The following is a description of a gene set: Mouse Gene Set: GOBP_MITOCHONDRION_ORGANIZATION A process that is carried out at the cellular level which results in the assembly, arrangement of constituent parts, or disassembly of a mitochondrion; includes mitochondrial morphogenesis and distribution, and replication of the mitochondrial genome as well as synthesis of new mitochondrial components. studied in species Mus musculus, and this is the list of marker genes: Sirt7, Bloc1s2, Ndufaf8, Endog, Ndufa13, Mrpl15, Slc25a31, Dap3, 2610042L04Rik, Ghitm, Snca, Bok, Atp13a2, Triap1, Pparg, Htt, Twnk, Sesn2, Camkmt, Septin4, Gclc, Lncbate1, Fancg, Man2a1, Mtm1, Fmc1, Adck1, Hdac6, Akt3, Dctn6, Prelid1, Hsp90aa1, Letmd1, Kif28, mt-Nd5, Chchd7, Mcu, Flvcr2, Timm50, Fbxo24 (F-box protein 24), Atp7a, Mapt, Golph3, Higd1b, Gabpb1, Primpol, Ndufa2, Irgm2, Thg1l, Tmem242, Pyroxd2, Bmf, Immt, Ptcd2, Kdr, Timm29 (translocase of inner mitochondrial membrane 29), Mief1, Ndufb9, Plaur, Bcs1l, Ndufa8, Sh3glb1, Tmem135, Pex5, Mff, Cox7a1 (NCBI Gene Id 12865), Ndufb11, Opa3 (NCBI Gene Id 403187), Ndufa11, Jtb, Cav2, Bnip3, Ndufaf4, Carlr, Bik, Epm2a, Nsun7, Nipsnap2, Micu1, Ddhd1, Chchd10, Atp23, Prmt6, Cebpa, Cyrib, Slc25a4, Akt1 (thymoma viral proto-oncogene 1), Ndufaf1, Lmna, Parp1, Mtx2 (metaxin 2), Vat1, Chchd4, Pld6, Afg3l2, Moap1 (modulator of apoptosis 1), Eya2, Proca1, Bid, Lipa, Gsk3b, Lyrm2, Ndufa5, Ndufa6, Ppargc1a, Ndufb6, Poldip2, Sdhaf4, Bcl2a1a, Mtx3, 4930550C14Rik, Cxadr, Opa1, Bcl2l10, Polg, Plscr3, Mtnap1, Ppp2cb, Surf1, Nectin2, Cp, Pnpt1, Igf1, Fastkd3, Rnaseh1, Ppif, Rab3a, Slc25a36, Stoml2, Tomm22, Dynlt1b, Ndufa3, Atp5if1, Acad9, Micos10, Atp5f1d, Ndufa9, Bax, Pet117, Neurl4, Cdk5, Plec, Norad, Cfh, Mir133a-1hg, Ednra, Ndufb11b, Bbc3, Mapk9, Mrpl39, Tmem102 (NCBI Gene Id 380705), Bcl2l13, Stat2, Fis1, Rnf7, Fas, Bcl2, Atf2, Fxn, Vps35, Mtfr1 (NCBI Gene Id 76994), Uqcc4, Rab29, Agk, Htra2, Pim2, Atg7, Ggnbp1, Stat3 (signal transducer and activator of transcription 3), Oxa1l, Cntnap1, Epas1, Hgf, Tmem14a, Mir361, Mtch1, Romo1, Selenon, Uqcc6, Park7, Marchf5, Tymp, Usp30, Dnm1l, Mfn1, Adgrg6, Psmd10, Mcl1, Ndufs2, Hrk, Hk2, Ndufa1, Dynlt1c, Lpin1, Agtpbp1, Spata18, Ndufs8, mt-Nd4, Bad, Ep300, Gclm, Fzd9, Mgme1 (NCBI Gene Id 98953), Mup3, Ctcf, Dynlt1a, Rab32, Dnaja3, ENSMUSG00000126352, Atad3a, Mmp9, Siva1, Mpv17l, Mtfp1, Mtfr1l, Mfn2, Ddhd2, Uqcc3, Bcl2a1c, Dynlt1f, Nubpl, Huwe1, Camk2a, Fsip1, Tert, Msto1, Marcks, Slc25a5, Polg2, Wasf1, mt-Nd6, Bcl2l1, Cox16, Aifm1, Pdcd5-ps, Bcl2l11, Gimap3, Pink1, Phb1, Pisd, Gdap1, Fam3a, Timm10, Cox10, Mfsd14a, Dnajc11, Atpaf1, Abcc9, Prkn, Ccar2, Apool, Map3k1, Aifm2, Hmgcl, Nptx1, Atg3, Ndufs6, Ndufc2, Fez1, Tmem11, Wdr81 (WD repeat domain 81), Mup5, Ier3, Mir668 (microRNA 668), Timm9, Bcl2a1b, Mef2a, Ndufb4b, Top3a, Mpv17, Rhot1, Ssbp1, Ndufaf7, Alkbh7, mt-Nd1, Rab38, Sfn, Tug1, Myc, Slc9a1, Slc22a5, Cert1, Ndufb3, Armcx3, Atp2a1, Rrm2b, Miga1, Avp, Uqcc5, Tafazzin, Nme3, Chchd2, Ndufb1, Tfam, Timm13, Pum2, Stox1, Vps13a, Cck, Pgam5, Col6a1, Hip1r, Lyrm7, Dna2, Cibar1, Irgm1, Ndufaf6, Noa1, Letm2, Cep89 (centrosomal protein 89), Ndufs3, Vps13c, Gper1, Hsd17b10, Slc25a33, Spg7, Vps54, Stpg1, Uqcc2, Mettl4, Ndufab1, Lig3, Sdhaf3, Tmem126a, Mul1, Ndufs5, Ap3b1, Tnfsf10, Ndufb8, Ndufb4, Apoo, Dmac2, Vdac2, Dcn, Cox7a2, Mllt11, Mrpl17, Ndufaf2, Lrrk2, Gpx1, Trmt10b, Bak1, Ndufb5, Jun, Vps13d, Ttc19, Ndufb4c, Pid1, Higd2a, Fundc1, Ndufs4, Igtp, Rap1gds1, Pycard, Slc35f6, Ggct, Nol3, Tomm70a, Rala, Cox14, Ndufb10, Zdhhc6, Foxred1 (FAD-dependent oxidoreductase domain containing 1), Pdcd5, Enpp1, Cdkn2a, Rab5if, Cox20, Tmem70, Sdhaf2, Atpaf2, Mir539, Pet100, Bcl2l2, Mir351, Ndufs1, Dhodh, Phb2, Cln8, Higd1c, Timmdc1, Mfsd8, Mup1, Pif1, Pnp, Samm50, Miga2, Coa3, Ppm1k, Chchd3 (coiled-coil-helix-coiled-coil-helix domain containing 3), Slc30a9, Coa5, Slirp, Cox17, Ndufaf3, Letm1, Ndufc1, Timm21, Supv3l1, Erbb4, Ndufb7, Mup2, Sdhaf1, Parl, Wdr35, Sharpin, Hspa4, Cluh, Oma1, Sco1, Trabd, Ndufb2, Pmaip1, Ndufaf5, Coq7, Maip1, Ucp2, Micos13, Higd1a, Rcc1l, Immp2l, Prdx3, Inf2, Them4, Capn10, Chchd6, Cd24a, Dmac1, Mtfr2, Tmem223, Ndufa11b, Coa4, Timm22, Aurka, Mup4, Hspd1, Afg3l1, Uqcrc1, Cryaa, Spata19, Mief2, Pla2g6, Zfp13 (NCBI Gene Id 240046), Ppp2r2b, Ralbp1, Myo19, Tmem186, Lonp1, Bnip3l-ps, Ndufs7, Cox18, Sco2, Pank2 (NCBI Gene Id 99040), Tomm40 (NCBI Gene Id 56712), Fam162a, Cox7a2l, P2rx7, Gba1, Sod2, Mup11, Trp53, Tmem126b, Gsk3a, Rhot2, Coa8, Tk2, Acaa2, Yme1l1, Taco1, Bnip3l, Stmp1 (NCBI Gene Id 67705), Smim20, Tfrc, Bcl2a1d, Spire1, Cntnap2, Cox19, Pde2a, Naif1, Ndufab1-ps, Ndufa10, Mtch2, Smad3, mt-Nd2, Cstad, Afg1l, Nrf1, Myh14, Cnp, Arrb2, Slc25a46, Mgarp, Mtx1, Coa6, Rrm1, Gimap5, Edn1, Uqcc1